Given this list of marker genes GABRG2, CDK19, GABRB2, NTRK2, NUS1, SCN1A, SLC38A3, EEF1A2, CNKSR2, KCNB1, AP3B2, FZR1, HCN1, CELF2, SYNJ1, SZT2, GABRA2, PACS2, KCNA2, CACNA1A, GRIN2D, SCN8A, CACNA1B, CLTC, FGF12, WWOX, DNM1, PARS2, DHDDS, YWHAG, SYNGAP1, CYFIP2, GABRA5, UBA5, AARS1, NECAP1, SCN3A, GABBR2, SLC1A2, KCNC2, GRIN2A, SLC13A5, PIGY, DALRD3, FOXG1, ATP1A2, PPP3CA (NCBI Gene Id 5530), TRAK1, CACNA2D1, FBXO28, ACTL6B, ATP1A3, ATP6V1A (ATPase H+ transporting V1 subunit A), here is a description of the gene set: EEG with multifocal slow activity Human Gene Set: HP_EEG_WITH_MULTIFOCAL_SLOW_ACTIVITY species: Homo sapiens Multifocal slowing of cerebral electrical activity recorded along the scalp by electroencephalography (EEG).